The following is a description of a gene set: studied in species Homo sapiens Downstream signaling of activated FGFR2 Human Gene Set: REACTOME_DOWNSTREAM_SIGNALING_OF_ACTIVATED_FGFR2, and this is the list of marker genes: FGF2, SOS1, FGF3, FRS2, FGF5, PIK3R1, PTPN11, FGF4, GRB2, FGF6, FGF20, FGF23, NRAS, PIK3CA, FRS3, FGF9, FGF22, PLCG1, FGFR2, FGF17 (NCBI Gene Id 8822), GAB1, HRAS, FGF1, KRAS, SHC1, FGF8, FGF18, FGF16, FGF10, FGF7